The following is a description of a gene set: Mouse Gene Set: GOMF_MAGNESIUM_ION_TRANSMEMBRANE_TRANSPORTER_ACTIVITY studied in species Mus musculus Enables the transfer of magnesium (Mg) ions from one side of a membrane to the other., and this is the list of marker genes: Nipal2, Slc41a3, Mmgt2, Trpm6, Mrs2, Mmgt1, Cnnm2, Nipa1, Slc41a1, Nipal3, Magt1, Nipa2, Trpm7, Tusc3, Zdhhc13, Nipal4, Cnnm4, Nipal1, Tmem94